The following is a description of a gene set: from publication Ben-Porath I, Thomson MW, Carey VJ, Ge R, Bell GW, Regev A, Weinberg RA (PMID 18443585) Human Gene Set: BENPORATH_NOS_TARGETS Set 'NOS targets': genes upregulated and identified by ChIP on chip as targets of the transcription factors NANOG, OCT4, and Sox2 (NOS) in human embryonic stem cells. species: Homo sapiens Cancer cells possess traits reminiscent of those ascribed to normal stem cells. It is unclear, however, whether these phenotypic similarities reflect the activity of common molecular pathways. Here, we analyze the enrichment patterns of gene sets associated with embryonic stem (ES) cell identity in the expression profiles of various human tumor types. We find that histologically poorly differentiated tumors show preferential overexpression of genes normally enriched in ES cells, combined with preferential repression of Polycomb-regulated genes. Moreover, activation targets of Nanog, Oct4, Sox2 and c-Myc are more frequently overexpressed in poorly differentiated tumors than in well-differentiated tumors. In breast cancers, this ES-like signature is associated with high-grade estrogen receptor (ER)-negative tumors, often of the basal-like subtype, and with poor clinical outcome. The ES signature is also present in poorly differentiated glioblastomas and bladder carcinomas. We identify a subset of ES cell-associated transcription regulators that are highly expressed in poorly differentiated tumors. Our results reveal a previously unknown link between genes associated with ES cell identity and the histopathological traits of tumors and support the possibility that these genes contribute to stem cell-like phenotypes shown by many tumors., and this is the list of marker genes: DHDDS, DHRS3, ZFP36L1, CDC14B, MTM1, SNRPN, UFM1, SKA2, YJU2, NANOG, CA2, PRPF38A, FGF2, LRRN1, ANO8, OBSL1, JUP, STAT3, USP7, PIPOX, ORC1, THBS2, URM1, BUB1B, SMIM3, ZEB2, MED12, OBI1, B3GALT4, HAS2, H2AJ, CABLES1, PTPN2, OGA, KANK1, FGFR1, EXOSC9, CAPZA2 (capping actin protein of muscle Z-line subunit alpha 2), GNG10, KIF15, MAN2C1, ICMT, REST, DUSP12, PHF8, TIMM23B, ATAD2, ZIC3, ZIC2, PPP2R1B, HESX1, RIC8B, FBXW11, LAMA4, CA4, FEZ1, OLFML3, DPPA4, ATP6V1G1, AASDH, MLLT10, KCNN2, PRDM14, SMARCAD1, TMEM170A, RAB5A, UBR5, GNPTAB, BMP7, SPRED1, KATNBL1, KIAA1143, POU5F1, CACNA2D1, SFRP1, JADE1, SRSF4, POLR3G, KLHL5, RBM22, RPS18, TALDO1, TAL1, CCN2, TBL1XR1, SLC44A1, IER5L, ZIC1, ICMT-DT, SGMS1 (sphingomyelin synthase 1), SOX2, DKK1, PPP2R3A, ADD3, DPYSL2, FGFR2, CPT1A, PLPP1 (NCBI Gene Id 94702), FRAT2, TCF7L1, TSC22D1, EOMES, KDM3A, FUS, RIF1, SFRP2, TRIM22, COMMD7, DTNA, BAMBI, NEBL, RPS3A, ENPP2, FOXO1, LHPP, CDK17, NFE2L3, COL12A1, LEFTY2, TNRC6A, KLF5, TAF12, DPH6, WDR36, LRFN3, PRR11, KAT6A, RESF1, CRIPTO, CSRNP2, TNC, SET, MSC, RNF24, LRAT, JPT1, UBE2D3, CAVIN3, NUCKS1, COMMD3, TRIM24, SKIL, CDYL, TLE3, LINGO1, KDR, ANKRD1, TCF20, GRHL2, RAD54B, DPYSL3, IRX2, NAALAD2, CDK14, RASGRF2, TOP2A, GJA1, NAXD, VPS52, GTPBP3 (NCBI Gene Id 84705), IFI16, EPHA1, FZD10, BUB3, ROR1, JARID2, ARID1B, SPAG9, CDC7, PNISR, USP44, PARG, LARGE1, HMG20A, DUSP6, HHEX, PDCL (phosducin like), SULF1, SALL1